Given this list of marker genes EXOC2, AAR2, NEK8, SSNA1, PSMD12, BBS2, ZYG11B, MCM2, ANKS3, EXOSC4, NUP88, PSMD8, BBS9, MKLN1, COX6C, APC, MYL6, MAPRE2, DVL3, IQGAP2, XPNPEP3, EXOSC7, GID8, NEK7 (NIMA related kinase 7), MKS1, AFG3L2, IFT27, NUDC, NUP133, VPS4A, EXOSC2 (NCBI Gene Id 23404), RBM14, COPS5, NEFM, MFAP1, POM121, H3-3A, SPATA7, CNOT1, MCM7, CNOT10, ARMC8, RAB8A, VAPB, TNKS1BP1, CDH23, EXOC6, DYNLT2B, EXOC6B, COPS7A, WEE1, MCM3, COPS7B, RMND5B, DDX5, NDUFA5, COPS3, DYNLT3, EFTUD2, FUZ, MYL6B, EXOC1, ARFGAP3, IFT43, TTC8, TIPRL, PGRMC2, RB1, TFAP2B, IFT57, TFAP2C, WNK1, LRPPRC (leucine rich pentatricopeptide repeat containing), DYNLRB2, PSMC4, DYNC1I2, IQGAP1, NEFL, EXOSC9, COPS8, DYNLL1, CD2BP2, ACSL3, MCM8, TFAP2D, CNOT9, APMAP, GLB1, IQCB1, CREBBP, UBE2D2, EFHC2, TRAF3IP1, DYNC1H1, IFT52, NINL, RMND5A, AIMP1, EXOC7, IFT20, TFAP2E, EXOC4, INTU (NCBI Gene Id 27152), BBIP1, CEP170, SNRPB2, EHD3, RPGR, MAEA, DYNC2I2, BBS7, TMED1, GLA, ARHGDIA, EIPR1, UBE2H, ARL8B, CALM1, EXOC3, PSMC6, ECHS1, MCM5, LZTFL1, YAP1, ERF, NME8, GID4, CBS, LCN2, EHBP1, COPS2, IFT70A, CTNNB1, UQCC1, YPEL5, MCM4, RANBP9, CTSA, SNAP29, HDAC2, PAFAH1B1, HDAC1, NDUFA9, IFT25, ANKS6, NFKB1, DCAF7, IFT172, DYNC1LI1, HTRA2, EXOC8, CCDC40 (NCBI Gene Id 55036), RAB2A, RAB14, GDI1, RANBP10, VIM, CEP170P1, CTBP2, LSM4, IQGAP3, MSH2, DYNLT1, WHRN (whirlin), CEP290, IFT122, IFT46, RAB3IL1, WDR26, DCAF11, COPS4, RABEP2, SMC4, RALB (RAS like proto-oncogene B), EIF5B, CEP97, EXOC5, DYNLL2, LCA5, DYNLRB1, BBS1, USH1C, AGPAT2, IFT80, STOM, IFT74, PSMD7 (proteasome 26S subunit, non-ATPase 7), PSMD13, DGKE, IFT140, DYNC2I1, CAMK2A, CNOT6L, IFT56, TFAP2A (transcription factor AP-2 alpha), BBS4, RNGTT, DNPEP (aspartyl aminopeptidase), IFT88, CDR2, ZMYND19, TBC1D4, IFT70B, RAC1, COPS6, RAB21, CLUAP1, RHBDD2, DOCK5, IFT22, IFT81, MCM10, MCM9, MCM6, BBS5, here is a description of the gene set: Ciliary landscape Human Gene Set: WP_CILIARY_LANDSCAPE species: Homo sapiens